Given this list of marker genes Fancc, Pdgfra, Tnfaip3, Ppif, Fbln5, Ppef2, Edn1, Txn1, Pjvk, Tet1, Pdgfrb, Prdx2, Sod2, Mapk7, Becn1, Hdac6, Hspa8, Kdm6b, Pex2, Foxa1, Rps3, Lrrk2, Akr1b1, Hdac2, Dhfr, Ect2, Crygd, Mapk9 (NCBI Gene Id 26420), Trap1, Gch1 (GTP cyclohydrolase 1), Klf2, Fos, Adprs, Plekha1 (pleckstrin homology domain containing, family A (phosphoinositide binding specific) member 1), Oser1, Mmp3, Fyn, Ogg1, Romo1, Ppargc1b, Mpv17, Txndc2, Fer, Smpd3, Ambp, Apex1, Sod3, Pink1, Gpr37, Zfp580, Ern1, Pex5, Ddr2, Foxp1, Stat6, Met, Nqo1, Ngb, Cfl1, Hk3, Top2b, Ptprk, Cygb, Prdx1, Abl1, Mapk3, Hsf1, Cyp1b1, Ankzf1, Cdk1, Psap, Capn1, Foxo3, Pawr, Sirpa, Pcgf2, Stk25, Prkcd, Ednra, Mapk1, Mt3, Map1lc3a (microtubule-associated protein 1 light chain 3 alpha), Sphk1, Atm, Zfp277, Trpm2, Cat, Trex1, Map3k5, Sod1, Agap3, Jun, Pdcd10, Axl, Trp53, Pex10, Aqp1, Hgf, Ezh2, Pdgfd (NCBI Gene Id 71785), Park7, Ucp1, Bnip3, Ripk1, Rack1, Net1, Il6, Map2k4, Mapk8, Mapk13, Endog, Setx, Il18rap, Sirt6, Slc8a1, Rhob, Atg7, Mmp9, Foxo1, Klf4, Cdkn2a, Prdx5, Pex13, Ercc6l2, Ep300, Pex12, Rela, Fxn, Nfe2l2, Rnf146 (NCBI Gene Id 68031), Trpc6, Fabp1, Apoa4, Akt1, Pex14, Trpa1, Prdx3, Gpr37l1, Anxa1, Btk, Mdm2, Atp7a, Aifm1, Ripk3, Lcn2, Cryge, Cbx8, Pcna, Egfr, Sirt1, Cd36, Prkaa1, Mmp2, Parp1, Gata5, Mpo, Pdk2, Crygf (crystallin, gamma F), Nme8, Mb (myoglobin), Nos3, Ccs, Chuk, Src, here is a description of the gene set: Any process that results in a change in state or activity of a cell (in terms of movement, secretion, enzyme production, gene expression, etc.) as a result of a reactive oxygen species stimulus. Reactive oxygen species include singlet oxygen, superoxide, and oxygen free radicals. species: Mus musculus Mouse Gene Set: GOBP_CELLULAR_RESPONSE_TO_REACTIVE_OXYGEN_SPECIES